Given this list of marker genes Atg14, Irs2, Agap2, Washc1, Irs3, Sh3glb1, Klf4, Pik3r1, Pik3ip1, Wdr81, Irs1, Prkd1, Wdr91, Lyn, Rubcn, here is a description of the gene set: species: Mus musculus Modulates the activity of a phosphatidylinositol 3-kinase (PI3K). Regulatory subunits can link a PI3K catalytic subunit to upstream signaling events and help position the catalytic subunits close to their lipid substrates. Mouse Gene Set: GOMF_PHOSPHATIDYLINOSITOL_3_KINASE_REGULATOR_ACTIVITY